The following is a description of a gene set: species: Homo sapiens Bifid ureter Incomplete duplication of the ureter. Human Gene Set: HP_BIFID_URETER, and this is the list of marker genes: FIBP, COL18A1, PAK2, PBX1, PORCN